Given this list of marker genes NAV3, MAP1B, TPPP, VASP, CKAP5, CDKN1B, MECP2, MTOR, BAIAP2L1, BIN1, ANKRD53, BAIAP2, CLIP1, CRACD, TPPP2, OCLN, CDC42EP5, FER, MLST8, MAPRE1, ARL2, NPHS1, NCK2, CDK5RAP2, CCR7, MAPT, NCKAP1L, NCKAP1, CDC42EP2, PAK1 (NCBI Gene Id 5058), PDE4DIP, C15orf62, RAC1, HSPA1A, PYCARD, CDK5R1, PRKCE, WASHC2C, TOGARAM1, GIT1, TPPP3, CDC42EP1, ALOX15, AKAP9, PSRC1, CSF3, LMOD1, CDC42EP3, CCL26, ARF6, EVL, KIRREL1, FES, PFN1, PTK2B, CTTN, CCL11, HCK, ARPC2, TENM1, SNX9, PINK1, BAIAP2L2, HSPA1B, CCL21, PFN2, TTBK1, SLAIN1, FCHSD1, DLG1, CDC42EP4, DCTN1, DRG1, CAV3, CCL24, FCHSD2, HSP90AA1, LMOD2, CLASP1, NUMA1, NCK1, AMBRA1, CARMIL1, CARMIL2, RPS3, SKA1, GRB2, BAG4, RICTOR, MET, SLAIN2, here is a description of the gene set: Any process that activates or increases the frequency, rate or extent of the process of creating protein polymers. species: Homo sapiens Human Gene Set: GOBP_POSITIVE_REGULATION_OF_PROTEIN_POLYMERIZATION